Given this list of marker genes REEP2, UMOD, RILPL1, RFTN1 (NCBI Gene Id 23180), ATP1B1, ARL6, CD24, RILPL2, here is a description of the gene set: species: Homo sapiens Human Gene Set: GOBP_PROTEIN_TRANSPORT_WITHIN_LIPID_BILAYER The directed movement of a protein from one location to another within a lipid bilayer.